Given this list of marker genes SLC5A2, here is a description of the gene set: The human gene SLC5A2 encodes a sodium-dependent glucose transporter (SGLT2), expressed in many tissues but primarily in the kidney, specifically S1 and S2 proximal tubule segments. It is a low affinity, high capacity transporter of glucose across the apical membrane, with co-transport of Na+ ions in a 1:1 ratio and is the main transporter of glucose in the kidney, responsible for approximately 98% of glucose reabsorption (reaminder by SGLT1). Defects in SLC5A2 are the cause of renal glucosuria (GLYS1; MIM:233100), an autosomal recessive renal tubular disorder characterised by glucosuria in the absence of both hyperglycemia and generalized proximal tubular dysfunction. Establishing definite genotype–phenotype correlations for GLYS1 is made difficult by variable expression of SLC5A2 and because other genes may have an impact on overall renal glucose resorption. Drugs that inhibit SLC5A2 are used to treat type 2 diabetes (T2D). The strategy to reduce hyperglycemia in T2D is to target renal glucose reabsorption by inhibiting SLC5A2 (Santer & Calado 2010, Calado et al. 2011). part of: SLC transporter disorders Reactome Pathway: Defective SLC5A2 causes renal glucosuria (GLYS1) studied in species Homo sapiens